The following is a description of a gene set: studied in species Homo sapiens Human Gene Set: GOBP_SUPRAMOLECULAR_FIBER_ORGANIZATION A process that is carried out at the cellular level which results in the assembly, arrangement of constituent parts, or disassembly of a supramolecular fiber, a polymer consisting of an indefinite number of protein or protein complex subunits that have polymerised to form a fiber-shaped structure., and this is the list of marker genes: ARF6, CYP1B1, NUP153, KRT12, PRKD1, AGFG2, ARPC4, TWF2, RHOBTB2, BAIAP2L2, FMN1, HSPA8, GPR65, P4HA3, KRT33A, CTNNA2, MYH11, SPIRE1, TAGLN2, MYBPC2, FSD1, HAUS6, CAP2, SVIL, FERMT2, KRT26, WASH6P, CDK5R1, CORO6, ROCK1 (NCBI Gene Id 6093), WIPF1, OCLN, FRMD7, SHROOM3, MYO15A, ARHGEF15, SERF1B, NLRP5, SPECC1L, CKAP2, BMP10, CRYAB, DBN1, JAK2, PLS1, TGFBR1, RIPK3, NCKAP1, MYOM3, ABI2, KRT28, HAUS8, B4GALT7, DIAPH3, SH3D21, RAC3, RNH1, STMN3, HAUS5, TMOD3, DYNC1H1, TCHH, P3H4, ELMO3, HSPA1A, MAPRE3, CALD1, SHANK3, LTBP2, PFDN2, TUBGCP6, TUBGCP3, CCSAP, KIF19, PHACTR1, KRT16 (keratin 16), FAM107A, SLAIN2, TNNT3, WASHC5, GOLGA2, AXIN1, ARHGAP28, ABL1, KCTD13, MYOZ1 (myozenin 1), CLU, AKAP13, DRG1, KRT37, KRT77, KRT84, FAT1, EZR, NAT8B, NEDD1, ITGB1, KRT75, TUBG2, SKA1, PALM2AKAP2, PPP2CA, RHOQ, TCAP, SDC4, KRT25 (keratin 25), BAG4, KRT15, MDM2, OAZ3, CAP1, KRT74, NEDD9, MECP2, LTBP4, KRT81, NDE1, XIRP2, PRPH, KRT85, FOXC1, MYOM1, SNCA, TNNT1, COL3A1, SHROOM2, MTPN, HAUS3, KRT4, COMP, COL14A1, PSEN1, LOXL3, TPPP2, TPM2, WDR1, CXCL12, ABITRAM, FHOD3, WHAMM, APOA1, WASHC4, KRT2, KRT20, IFT172, TLL1, GIT1, ARHGAP18, BBLN, BCL2, DNAI3, CDC42EP5, NKX2-5, KANK2, PHLDB2, PRKCE, VILL, STMN2, CASQ1, KRT32, PDGFRA, HDAC6, PAWR, KIF21A (kinesin family member 21A), TUBG1, PFDN4, KRT13, CAMSAP3, KPNB1, FES, PLOD1, KHDC3L, INA, ARHGEF7, NPHS1, DMTN, KRT19, SCIN, SPEF1, KRT1, TOGARAM2, ATXN7, GFAP, KRT10, RAB11A, CCDC66, AKAP9 (A-kinase anchoring protein 9), KRT23, FMN2, WASHC1, CSRP3, HOOK1, ARPIN, TMSB10, CCDC13, MAD2L2, PPM1F, TTBK2, SPTBN4 (NCBI Gene Id 80322), CST3, SHANK1, CCDC57, CHP1, LOXL1, PRKCD, DDR2, LIMCH1, ZBED3, KIF24, MYBPC1, MYO1B, PARK7, KRT17, COL11A1, TRIM27, GHSR, KASH5, INF2, FKBP10, NCKAP1L, GMFG, CAPZB, CDC42EP1, ADD2, WASF3, CARMIL1 (NCBI Gene Id 55604), SYNPO, LMOD3, EPHA1, FCHSD1, PFDN1, FKBP1A, TRIOBP, CAPZA3, BAIAP2L1, ADAMTS14, CCN2, HCK, DPYSL3, PLEK (pleckstrin), TPPP3, LUZP1, TARDBP, KRT40, TMEFF2, EXT1, AQP5-AS1, MAP6D1, EPS8, CEP120, KRT39, CFLAR, VIL1, PLA2G1B, TMSB15C, TRPV4, TMOD4, CD47, TLL2, PRUNE1, PSRC1, CIB1, SPTAN1, CCDC88C, COLGALT1 (collagen beta(1-O)galactosyltransferase 1), NEB, MEF2A, MYO7B (myosin VIIB), CCL11, VBP1, RND2, USP8, ASB2, ELMO1, PKP2, SPIRE2 (NCBI Gene Id 84501), CLASP2, MAGEL2, CEP126, CDSN, NEFL, MARCKS (myristoylated alanine rich protein kinase C substrate), GPX1, RHOBTB1, KRT7, LOXL4, MYBPC3, F2RL1, KRT80, PLEKHH2, TMOD1, TTC17 (NCBI Gene Id 55761), MET, ARRB1, GAS2L2, ERMN, HAX1, AIF1, BFSP1, SLC39A12, WDR47, GMFB, PACSIN1, ARPC5, CRTAP, CCR7, HDGFL3, RUFY3, SHH, INPPL1, CCL24, FSCN3, OBSL1, MYBPH, KRT86, APC (APC regulator of WNT signaling pathway), TSC1, PPM1E, ANTXR2, TGFB2, CEP192, ALOX15, CCDC88B, KIF2C, KANK4, CAPZA2, ANG, ARAP1, S1PR1, ROCK2 (Rho associated coiled-coil containing protein kinase 2), HAUS1, CDC42EP2 (NCBI Gene Id 10435), SFRP1, BACE1, EDN1, PAK1, TNFAIP6, GBA2, PTGER4, ESPNL, ADPRHL1, CARMIL2, TUBB1, IQGAP3, PDCD10, CAPZA1, COTL1, SLK, AP1AR, RHOF, TENM1, RHPN2P1, MIR31 (microRNA 31), WNT4, CCL26, GREM1, CCL21, SYNPO2, ADAMTS3, ESAM, COL2A1, KANK3, KATNA1, WASH3P, CSNK1D, NAA80 (NCBI Gene Id 24142), ITGB5, SPTBN1, TNXB, P3H1, MAP10, BRAF, USH1C, CSRP1, NAV3, RGCC, PAFAH1B1, MMP11, PDE4DIP, MYO1H, RICTOR, LIMA1, BFSP2, KATNAL2, RHOC, PIK3R1, TPX2, ACTA1, PAK3 (NCBI Gene Id 5063), CLIP2, NEBL, ANKRD1, ARHGEF2, FURIN, P4HA1, IQGAP2, NCKAP5, SHTN1, SEMA5A, KRT76, CD2AP, DCTN1, PFN2, SPTBN2, HSPG2, COL1A2, FSCN2, BCAR1, MLST8, NCKAP5L, SLIT2, PPP1R9B, MIR1-1, LOXL2, SSH2 (NCBI Gene Id 85464), TAGLN3, RAC1, ADAMTS7, ALMS1, SRC, TPPP, RHOA, MID1, KATNBL1, PLOD2, MYO5A, PFN3, HOOK2, PCNT, RHPN2, TOGARAM1, TTN, WASF1, TLE6, COL5A3, ELMO2, ADAMTS19, ARFGEF1 (ADP ribosylation factor guanine nucleotide exchange factor 1), PPFIBP1, ENAH, DLG1, MYH3, SLC9A1, SYNPO2L, KRT83, DAPK3, CLIP3 (CAP-Gly domain containing linker protein 3), FHOD1, CNN3, ARHGEF18, BMERB1, CAMSAP2, NDEL1, SPTB, KPTN, MYO1E, AVIL, KRT78, EMD, MYH6, NF1, F11R, TUBA1A (tubulin alpha 1a), EVL, PLS3, PXDN, MYO1C, JMY, TACR1, DNM2, USP9X, EMILIN1, PKP1, BBOF1, DAAM2, DYRK1A, MTM1, AMOT, GAS2L1, CENPJ, LCP1, RANBP9, MICAL1, CDKN1B, SAMD14, RND3, CDKN2A, TUBGCP5, ANKRD23, LUM, KRT79, NIN, B2M, WASHC2C (WASH complex subunit 2C), COLGALT2 (collagen beta(1-O)galactosyltransferase 2), MAPT, ARFIP1, ZNF207, TTC8, VIM, TPM4, TACSTD2, SORBS1 (NCBI Gene Id 80057), TAOK1, MICALL2, ESPN, ARFIP2, ACTR2, BBS4, EEF2K, KBTBD13, MSRB1, MYL9, KRT34, PDXP, SMAD3 (NCBI Gene Id 51521), STMN1, PIK3R2 (phosphoinositide-3-kinase regulatory subunit 2), CORO1C, TPM3, CYRIA, ELN (NCBI Gene Id 2006), CDC42EP4, DPT, RB1, CFL1, RAC2, CFL2, MIR149, KRT38, KRT31, RHOB, MFAP4, KATNAL1, CKAP5, BAX, TMSB15A, DSG3, MAP7D3, HSPA1B, TMOD2, ADD3, CAMP, MYOC, LPAR1, XIRP1, CHADL, MAP1A, FHDC1, MYO1G, WAS, HAUS4, KIF14, APOE, KIRREL1, WASF2, TRDN, CLIP1, CDC42EP3, COL11A2, CARMIL3, MSRB2, TPM1, TMSB4X, KRT3, MTOR, KRT27, ARF1, INPP5K, TUBB4A, CAPG, CYFIP2, MYO6, BIN3, EML2 (NCBI Gene Id 24139), KIF18A, RHOH, CSRP2, ARPC3, RPS3, WASHC2A, RASA1, KLHL41, DIAPH2, PPP2CB, CHRNA7, ACTC1, KIF2A, RHOJ, VASP, SSNA1, TUBGCP4, ARPC1A, KRT9, PFN1, CSF3, FLII, DSP, RHOU, AIF1L, PDLIM1, ACTR3, KRT71, ARHGAP35, MYO1A, NF2, FAM171A1, ALDOA, PGM5, SPTA1, KRT72 (keratin 72), BAIAP2, SPAST, FSCN1, KRT36, MIR29B1, MTSS1, RHOD, VPS33B, CAMSAP1, AQP2, MAP1B, PLEC, SIX4 (SIX homeobox 4), SPATC1L, ERO1A, PPP1R9A, PFDN5, S100A10, ARPC2, SERPINH1, SLAIN1, EMP2, MZT1, CLRN1, MYPN, RFLNA, STMN4, KIF2B, MYO1F, RIPK1, FKBP4, DLC1, PRKAR1A, BASP1 (brain abundant membrane attached signal protein 1), VIPAS39, PLOD3, GAS2L3, HSP90AB1 (heat shock protein 90 alpha family class B member 1), ABI1, RGS4, CATIP, TRIM54, MYOZ2, TWF1, DES, EPPK1, NEFH, APP, RAP1GDS1, ARL2, PIK3CA, CORO1B, FLNC, COBL, GRB2, PCM1, DSTN, CTTN, RND1, SORBS3, CLIP4, FER, BIN1, CD36, FMOD, C9orf72, RDX, TJP1, ARHGEF10L, KRT6A (keratin 6A), SCX, LATS1, MYOM2, TBCB, CDH5, ZEB2, TRPV3, LIMK2, TLN1, OPTC (opticin), HIP1R, HOOK3, WASL, MICAL2, TAC1, SHROOM1, ACTN1, MYLK3, SRF, CX3CL1, CAV3 (NCBI Gene Id 859), CUL3 (cullin 3), FCHSD2, PYCARD, BMP1, SFRP2, TMSB15B, MIR214, MYO5C, NAT8, ASAP3, CNN1, RFLNB, TBCD, RHPN1, LMOD2, CLASP1, COL1A1, COL6A1, LOX, INPP5J, HAUS2, LDB3, ACTN2, NUMA1, MIR21, HAUS7, TESK1, HIP1, OBSCN, SHROOM4, ADAMTS2, FBLN5 (NCBI Gene Id 11268), HCLS1, ARHGAP6 (NCBI Gene Id 395), CORO2B, SNX9, ARHGAP12, ANKRD53, PTK2B, PAK2, KRT24, FLNA (filamin A), IQGAP1, APC2, KRT6B, ATP7A, FUS, KRT5, ITGB1BP1, MAP1S, LIMD2, KRT82, GDPD2, ARPC1B, NRAP, ZYX, SMAD4, BLOC1S2, GHRL, TNNT2, LMOD1, MYH10, OOEP, GSN, MIR138-1, LIMK1, PROX1, POF1B, AGFG1, KRT14, HSP90B1, MAP2, MICAL3, SELENON, MYO7A, TREM2, MYL2, SSH3, ADD1, CYFIP1, WASHC3, PLK3, DIAPH1, CORO1A, CDK5RAP2 (NCBI Gene Id 55755), FOXC2, VHL, MYO5B, MFAP5, BID, COL5A1, SIAH1, MAP4, GAS2, WDR73, CORO7, MAPRE1, KRT35, AURKB, NME7, PXN, KIF18B, NRP1, CRACD, PPFIA1, ANXA2, KRT33B, PIN1, COL5A2, ARHGAP25, BRK1, KRT6C, CRIPT, RAPGEF3, SIAH2, KATNB1, CAPN3, BLOC1S6, FGF13, SERPINF2, PRKCI (NCBI Gene Id 5584), SERF1A, PREX1, TMSB4Y, MKKS, ADAMTS12, CNN2, NCK2, CCDC88A, DVL1, PICK1, SPTBN5, PDGFRB, PLEKHG2, ARHGAP40, MIR20A, EFEMP2, CGNL1, SH3KBP1, SWAP70, WIPF3, MYADM, LDLR, AEBP1, CDC42, KLHL24, MARCKSL1, NEFM, PDLIM3, RHOG, SSH1, FBXO5, KRT73, ACTG1, IAPP, TGFB3, DNAJB6, SH3BP1, TUBGCP2, PRKN, CRYAA, PFDN6, MYO19, NCK1, COL12A1, KANK1, THSD4, RHOV, ARHGEF5, ARPC5L, MID1IP1, CYRIB, ARHGEF10, MYO1D, C15orf62, TNFAIP1